Given this list of marker genes SOS1, NRAS, CDKN1A, HRAS, KRAS (NCBI Gene Id 3845), GRB2, MYO18A, GOLGB1, PIM1, GAB2, SPTBN1, ZMYM2, PIK3R1, ETV6, STAT5B, NOX4 (NCBI Gene Id 50507), STAT5A, TRIP11, PIK3CA, here is a description of the gene set: Signaling by FLT3 fusion proteins Human Gene Set: REACTOME_SIGNALING_BY_FLT3_FUSION_PROTEINS studied in species Homo sapiens